Given this list of marker genes Arid4b, Qrich1, Trpm2, Casp4, Kcnb1, Mecp2, Runx1, Slitrk5, Onecut2, Als2, Mapkapk2, Gucy2c, Iqck, Snurf, Lss, Nrip3, Apbb2, Cnot2, Arl4a, Gabra5, Rcor1, Kcmf1, Cep72, Lmo2 (LIM domain only 2), Pou3f4, Mpzl1, Prkaa2, Siah1a, Scn7a, Rock2, Gabra2, Jdp2, Fcgr1, Sdr9c7, Inpp5f, Slc7a2, Nckap1, Pxylp1, Klhl42, Zfp568, Six3, B3gat3, Fat3, Wdfy1, Entpd7, Shtn1, Marchf2, here is a description of the gene set: studied in species Mus musculus from publication Chen Y, Wang X (PMID 31504780) Mouse Gene Set: MIR_3967 Genes predicted to be targets of miRBase v22 microRNA mmu_miR_3967 in miRDB v6.0 with MirTarget v4 prediction scores > 80 (high confidence targets).